Given this list of marker genes Hdac3, Helz2, Tbl1x, Ncor2, Ncoa1, Sin3a (transcriptional regulator, SIN3A (yeast)), Carm1 (NCBI Gene Id 59035), Med1, here is a description of the gene set: electronically inferred by orthology from the curated human pathway studied in species Mus musculus Reactome Pathway: Regulation of lipid metabolism by PPARalpha This event has been computationally inferred from an event that has been demonstrated in another species.<p>The inference is based on the homology mapping from PANTHER. Briefly, reactions for which all involved PhysicalEntities (in input, output and catalyst) have a mapped orthologue/paralogue (for complexes at least 75% of components must have a mapping) are inferred to the other species. part of: Metabolism of lipids